The following is a description of a gene set: Abnormality of the corpus callosum. species: Homo sapiens Human Gene Set: HP_ABNORMAL_CORPUS_CALLOSUM_MORPHOLOGY Abnormal corpus callosum morphology, and this is the list of marker genes: AFG2B, FAT4, PLPBP, UGP2, SRPX2, SUPT16H, CDK13, KIDINS220, HNRNPR, RAB3GAP2 (NCBI Gene Id 26114), DNA2, TBC1D23, KIAA0586, YIF1B, IFT80, TMEM147, WDR73, SAMHD1, PCGF2, DCHS1, MAG, CCDC47, NFU1, PIGN, CAMK2A, ATPAF2, GBA2, GTPBP2, MRPS25, ZFYVE26 (NCBI Gene Id 338378), SMC1A, BRAT1, YWHAG, NAE1, GALC, CEP135, PNKP (NCBI Gene Id 11284), PPP2R1A, RAB3GAP1, WDR81, MTRFR, CENPF, RNF13, LMBR1, TUBA1A, GDF1, SEC31A, ANKLE2, PPFIBP1, GET4 (NCBI Gene Id 51608), IFT74, POLRMT (RNA polymerase mitochondrial), POLR1A, CPLX1, TAF8, TIAM1, DYNC2I1 (dynein 2 intermediate chain 1), KMT2A, CFC1, CTNNA2, KCNA1, RNASEH2A, COPB2, MOCS1, ZFX, WWOX, KCNB1, PITX1, HNRNPK, PDPN (NCBI Gene Id 29912), LNPK, ZNF423, ACTG1, GABRG2, SIX3, USP9X, HYLS1, DEAF1, AIMP1, TREX1, BMP4, ALDH18A1, WARS1 (tryptophanyl-tRNA synthetase 1), AMPD2, MOCS2, POU1F1, HNRNPU, MT-TF, L2HGDH, KDM1A, LMBRD2, DHX16, TP73, CEP290, MDH1, TSEN2, NRROS, KAT8, ARID1B, PGAP3, RARS1, DHDDS, CRPPA, BCOR, GTF2H5, PRUNE1 (prune exopolyphosphatase 1), NONO, EFNB1, ATP6AP2, OFD1, SNIP1, TARS1, AP4M1 (adaptor related protein complex 4 subunit mu 1), ACO2, PIK3R2, EIF2AK2, COASY, GRIK2, MT-CO3, EHMT1, PYCR2, FLNA, TARS2, GLI2, SLC35A2, SPG11, AHSG, NR2F1, ATRX, RNU12, SLC35B2, YY1, SZT2, APC2, CHKA, DACT1, SLC30A9, GFM2, NPHP1, ERLIN2, RB1, PLCH1, POLG2 (NCBI Gene Id 11232), BLTP1, KIF14 (kinesin family member 14), GJC2, ATP6V1A, MAN2B1 (NCBI Gene Id 4125), VPS41, STIL, RMND1, ACY1, IGF1R, TMX2, GLYCTK, KCNT2, CNOT3 (NCBI Gene Id 9756), TMEM218, CACNA1I, FA2H (NCBI Gene Id 79152), DDX3X, FANCD2, B9D2, SLC25A22, EP300, CYP2U1, FDXR, OPA1, KCNT1, DONSON, PROP1, SMO, CDK5, MTOR, HECTD4, DNAJB4, SLC13A5, NALCN, RNU4-2, SASS6, WDR26, FGFR1, SH3PXD2B, VPS11, GOLGA2, LSM11, DDX6, SMARCA4, SOX2, SMG9, ATAD3A, PIGP, ACTL6B, DHCR7, UNC80, CTU2, DPAGT1, CAMSAP1, FANCI, FRMPD4, SSR4, MAF, WDR45B, MCPH1, NDUFA8, NELFA, IGBP1, POMGNT1, UPF3B, EPRS1, KIF2A (NCBI Gene Id 3796), DALRD3, RBM10, GTF2E2, NDUFA2, PGAP2, CCND2, VPS51, DDHD2, KMT2C, PLAA, IFT27, U2AF2, PDHB, CEP120, CEP104, GRIA3, ODC1, MT-ND6, ZBTB20, ASPM, PLP1, LAMB1, PRPS1, CD96 (NCBI Gene Id 337949), MT-TW, CDON (cell adhesion associated, oncogene regulated), DOHH, TCTN1, NFIA, GPC4, ECHS1, GGT1, TMTC3, SPTAN1 (NCBI Gene Id 6709), GFM1, UBA5, FLII (FLII actin remodeling protein), MYT1L, PSAP, SETD2, VANGL2, DPYSL5 (NCBI Gene Id 56896), GAD1, SLC6A8, SCAF4, TREM2, AP5Z1, PNPT1, ARID1A, EXOC7, STAMBP, SCYL2, DDB1, IFT52, PEX1, TSEN15, PARS2, DENND5A, POMT1, RAI1, GABRA2, PIK3C2A, MRAP, IDS, AXIN1 (NCBI Gene Id 8312), ADAT3, SVBP, KIAA0753, HCN1, DPYD, PHGDH, DOCK7, LYRM7, FLVCR2, POGZ, MCOLN1, STXBP1, TRAPPC6B, MCM7, AFG2A, ZEB2, MT-TH, ARL13B, NT5C2, LONP1 (NCBI Gene Id 9361), DARS1, HIVEP2 (NCBI Gene Id 3097), NMNAT1, CHD3, CRIPTO, PLCB1, TMEM216, CELF2, TYROBP, EXOSC9, BCAP31, TBCE, TRIP13, FGFRL1, NDE1, OSGEP, TOPORS, STUB1, PIGL (phosphatidylinositol glycan anchor biosynthesis class L), MAPRE2, HUWE1, GLDC, FKTN, NSRP1, SLC4A10, POMT2, TBCD, NRAS, BCL11B, HID1, UBTF, GLB1, HDAC4, TCTN2, ZNF526, DPF2, CTNNB1, EARS2, KIF5A, FBXW11, ACER3 (alkaline ceramidase 3), OTX2, ALG2, TGFB1, WDR4, GOT2, C12orf57, NKX2-1, PCLO, SON, USP7, AMER1, L1CAM, SLC25A46, RERE, SIN3B, RPGRIP1L, QARS1, METTL5, ERCC6, PGAP1, TUBA8, ROBO1, ALDH7A1, MDH2, HSPA9, RBL2, WAC, TRAPPC10, KAT6B, H3-3A, CEP57, PLXNA1, LSS, EIF2B4, KDM5A, VRK1, NOVA2, SPG21 (SPG21 abhydrolase domain containing, maspardin), RNU4ATAC, GPT2, NODAL, GMPPB, CNOT1, POMK, KNL1, TMEM138, TUBGCP2, GBA1, NUP188, TNR, NUP37, FGFR2 (fibroblast growth factor receptor 2), ATL1, MTHFS, VPS53, LYSET, RNASEH2B, SCN1A (NCBI Gene Id 6323), SLC12A5 (solute carrier family 12 member 5), NHLRC2, PIGG, TRMT10A, FGF8, ERCC5, GLI3 (NCBI Gene Id 2737), SLC25A1, POU3F3, PAH, DAG1, MACF1, MRPS22, RAP1B, MID1, CDH2, TBX4, PIGQ, MED25, SNAP29, SACS, CYFIP2, CAMLG, MAP1B, ERMARD, MAST1, MT-TL1, GRIN2D, POLR2A, PPIL1 (NCBI Gene Id 5482), TMEM70, NDUFAF5, CLCN3, DARS2, KIFBP, EML1, RPS6KA3, EXOSC8, CDK6, ADCY5, B4GAT1, TRAPPC12, PPP2R5D, ADARB1, ERCC3, MT-TS2, ZNF462, MED27, DLL1, ACBD6, PUF60, PPP1R21, DYRK1A, MPLKIP, SOX11, MT-CO1, POLR3B, RECQL4, AP4S1, COG8, TXNDC15, ARX, HRAS, PI4KA, NTRK2, ABAT, GFER, COG6, TRIM8, MED23, DYNC2I2, LRRC32, NDUFB11 (NCBI Gene Id 54539), PPP2R3C, CDK5RAP2, DNM1, TMEM67, CSPP1, RAB18, TBC1D20, HERC1, FOXA2, NFIX, RUSC2, CDKL5, AP4B1, FTH1, HSPG2, H1-4, KDM3B, INTS11, PIEZO2, PTCH1, NFIB, NECAP1 (NECAP endocytosis associated 1), DEPDC5, ALDH6A1, KAT5, LETM1, FH, SETBP1, POLR3K, GPC3, TSEN54 (tRNA splicing endonuclease subunit 54), UBE3A, TUBB3 (tubulin beta 3 class III), NSUN2, TRRAP (transformation/transcription domain associated protein), RAB11B, PRORP, KCNQ2 (NCBI Gene Id 3785), SALL1, CUL4B, HPDL, MAN2C1, KIF5C, CILK1, SNF8, DHCR24, NRCAM, TCF4, FRMD4A, EXOC8, MAP2K2, DIS3L2, RNF220, NAA10, LMNB1, POMGNT2, CDK8, RAB34, STAG2, MOGS, SLC25A24, PAFAH1B1, HCCS, SIX6, NDUFB7, CNP, GRIN2A, SUZ12, MPDZ, ASXL1, ZNF148, SLC12A2, WDR35, PTPN23, MT-CYB (NCBI Gene Id 4519), VAC14, IBA57, FCSK, CASK, THUMPD1, ARSI, CYP11A1, ACTB, FGF12, NUS1 (NUS1 dehydrodolichyl diphosphate synthase subunit), PIGA, COL4A1, SYT2 (NCBI Gene Id 6858), NEXMIF, VPS13B, CRIPT, CTCF, CPT2, CCDC88A, RNU7-1, PRMT7, TOE1, AP1G1, SCO2 (synthesis of cytochrome C oxidase 2), BUB1, KIF26A, VPS50, FBXL4, SARS1, AIFM1, RNASEH2C, CACNA1A, TBC1D7, RTTN, MED12L, PACS2, PLCB4, PMS2, GABRB1, OSTM1, PROKR2, SYNJ1, KRAS, LMNB2, SMARCC2, IFIH1, NSD1, ATN1, SMARCD1, SYNGAP1, AHDC1, TOGARAM1, ZSWIM6, TAF1, SCN3A, SPEN, SKI, RPGRIP1, MT-TQ, LRP2 (LDL receptor related protein 2), EIF4A2, PI4K2A, MRPS16, ITGB6, OTUD6B, HK1, AP3B2, GNPTAB, BCAS3, LARGE1, SNUPN, UBE4B, DDX59, PIGB, IFT140, PRKDC, DCC, HHAT, PDE6D, CDC42, GABBR2, MEF2C, LIG4 (DNA ligase 4), FOXH1, GAS1, TCF12, DIAPH1, BUB1B, VPS4A, EXTL3, ZMIZ1, CDC42BPB, HTRA2, CARS1 (cysteinyl-tRNA synthetase 1), SLC5A6, HS2ST1 (heparan sulfate 2-O-sulfotransferase 1), NADK2, WNT3, HIC1, LIG3, PIK3CA, EBP, MTHFR, FKRP, EIF2S3, KCNAB2 (NCBI Gene Id 8514), TUBB2A, TUBB, TSEN34, TTC5, CACNA1E, LRPPRC, FOXG1, CEP152, CNKSR2 (connector enhancer of kinase suppressor of Ras 2), TBCK, B9D1, MT-ND4, AKT3, BRD4, CWF19L1 (NCBI Gene Id 55280), TAF13, AHCY, CREBBP, POLR3GL, CNTNAP2, SHMT2, NF1, BUB3, ZFR, ARL3, SV2A, SLC25A19, FOSL2, NEDD4L, HESX1, ADNP, ZDHHC9, NUDT2, COG2, UBE3B, DYNC1I2, NEUROD2, ATP1A3, ALG8, DMXL2, IRF2BPL, WLS, DCX, VAMP2, HIBCH, PRRX1, YARS1, PRKCZ, FZR1, CEP41, GLRX5, DVL1, ZIC2, KATNB1, PUM1, RNF113A (NCBI Gene Id 7737), RXYLT1, KANSL1, ATG7, SIK1, ATP11A, BRF1, TGIF1, MED12, CDK10, ALX1, DNAL4, FGFR3, TCTN3, KCNA2, CEP85L, KCNK4, POLR1C, MKS1, AIMP2, C2CD3, BRAF, ATP9A, FIG4, PCNT, DPH2, ADAR, EEF1A2, ARNT2, CACNA2D1, MT-ND1, HSD17B4, NSD2 (nuclear receptor binding SET domain protein 2), TRAPPC9, VARS2, MAPKAPK5, AGTPBP1, PEX2, MYCN, KCTD7, PPP1R12A, BRPF1, SLC1A4, ABHD16A, PUS3, SMARCE1 (SWI/SNF related, matrix associated, actin dependent regulator of chromatin, subfamily e, member 1), WT1, GABRD (NCBI Gene Id 2563), SLC38A3, LHX3, MT-ND5, GCSH (glycine cleavage system protein H), CLTC, COX7B, TMCO1, VARS1, TUBB2B, PPP2CA, GPSM2, GABRB2, EMC1, PRDM16, FRA10AC1, KMT2D, ALG12, DISP1, TTI2, NTN1, TEFM, GLUL, ATP1A2, EPG5, RELN, COG7, RSPO2, WBP4, CHMP1A, CDK19, PDHX, SUFU, CIT, PSAT1, NANS, COG4, THOC6, ASNS, SLC9A6, ARMC9, RAD51, LHX4, TMEM107, ERCC2, LUZP1, SLC25A10, PLK4, UBE3C, CASZ1, SHOC2, RAC3, GNAO1, SIN3A, RSPRY1, ZNF699, EXOSC1, ALX3, ATP8A2, ZBTB18, ALG3, ARID2, ESAM, SRPK3, BICD2, TMEM106B, SMARCB1, RHOBTB2, FLI1, PORCN, ALX4, TRAPPC14, CLP1, ARHGAP31, CTBP1, SCN8A, FLCN, MINPP1, RAB23, SLC32A1, RAC1, KATNIP, KIF15, COG3, MAST3, GRIN1, DNM1L, IQSEC2, OCA2, KDM4B, NKX6-2 (NCBI Gene Id 84504), CSF1R, PIGH, CPSF3, CCDC174, KCNC2, AARS1 (alanyl-tRNA synthetase 1), SCN1B, TAF2, HACE1 (NCBI Gene Id 57531), KDM6A, CACNA1B, VAX1, EXOSC3, ZNHIT3, TMEM231, TMEM237 (transmembrane protein 237), ANKRD11, KDM5B (lysine demethylase 5B), PAX6, PDHA1, OTUD5, PIGU, SOX4, GPKOW, PDYN, PPP3CA, CEP63, SLC12A6, GRIA4, VWA3B, GPX4, SF3B2, DYNC2H1, CLCN4, POLR3A, WDR62, TUBG1, EXOC2, RORA (RAR related orphan receptor A), SOX3, CNTNAP1, FANCB, YWHAE, PPP1R15B, OTUD7A, PHC1, SEPSECS, TMEM260, CPLANE1, SMARCA2, SLITRK2, FBXO28, ZNF335, GABRA5, PEX16, C2orf69, INPP5E, RALGAPA1, B3GLCT (NCBI Gene Id 145173), COQ4, PIBF1 (progesterone immunomodulatory binding factor 1), EOMES, NARS2, MAPK8IP3, TECPR2 (tectonin beta-propeller repeat containing 2), PYCR1, MBTPS2, SLC6A9, CBY1, KMT2E, SLC1A2, B3GALNT2, CENPE, REPS1, AMFR, DYNC1H1, ATP13A2, ZIC1, GON7, PTDSS1, CDC40, TRAK1, TBC1D24, MFSD2A, CC2D2A, NCAPD3, GRM7, ASXL3, SCN2A, DPH1, FDFT1, MMP23B, IER3IP1, EMX2, MLH1, NARS1, MT-CO2, ARFGEF2, FAM149B1, AP4E1, SHH, KPNA3, KIF7, AHI1, ITPR1, CARS2